Given this list of marker genes Tab1, Rps27a, Tab2, Ubc, Map3k7, Uba52rt, Uba52, Traf6, Tab3, Ubb, Irak2, here is a description of the gene set: studied in species Mus musculus IRAK2 mediated activation of TAK1 complex Mouse Gene Set: REACTOME_IRAK2_MEDIATED_ACTIVATION_OF_TAK1_COMPLEX